Given this list of marker genes CYP46A1, OSBPL7, AMACR (NCBI Gene Id 23600, alpha-methylacyl-CoA racemase), MIR33A, SIRT1, SLC27A5, FGFR4, SLC27A2, STAR, OSBPL6, CYP8B1 (NCBI Gene Id 1582), ERRFI1 (ERBB receptor feedback inhibitor 1), ABCB11, AKR1C4, CYP7A1, CYP27A1, BAAT, PROX1, OSBPL3 (NCBI Gene Id 26031), SCP2, ACOX2, ACOT8, ABCD3, NR1D1, CYP7B1, OSBP, CES1, CYP39A1, OSBPL9, HSD3B7, MALRD1, OSBPL1A, FGF19, AKR1D1, NR1H4 (nuclear receptor subfamily 1 group H member 4), HSD17B10, OSBPL2 (NCBI Gene Id 9885), STARD4, here is a description of the gene set: studied in species Homo sapiens The chemical reactions and pathways resulting in the formation of bile acids, any of a group of steroid carboxylic acids occurring in bile. Human Gene Set: GOBP_BILE_ACID_BIOSYNTHETIC_PROCESS